The following is a description of a gene set: studied in species Mus musculus electronically inferred by orthology from the curated human pathway part of: Aerobic respiration and respiratory electron transport Reactome Pathway: Pyruvate metabolism This event has been computationally inferred from an event that has been demonstrated in another species.<p>The inference is based on the homology mapping from PANTHER. Briefly, reactions for which all involved PhysicalEntities (in input, output and catalyst) have a mapped orthologue/paralogue (for complexes at least 75% of components must have a mapping) are inferred to the other species., and this is the list of marker genes: Ldhb, Armc8, Gid4, Gstz1, Gpt, Pdpr, Rps27a, Pdp1, Pdha1, Vdac1, Fahd1, Pdk2, Pdk4, Ubb, Ldhc, Ldha, Dld (dihydrolipoamide dehydrogenase), Pkm, Sirt4, Dlat, Pgam5, Rmnd5b, Ldhal6b, Ranbp9